The following is a description of a gene set: Any anomaly of the P wave of the EKG, which results from atrial depolarization. The P wave occurs when the sinoatrial node creates an action potential that depolarizes the atria. species: Homo sapiens Human Gene Set: HP_ABNORMAL_P_WAVE Abnormal P wave, and this is the list of marker genes: SCN5A, GJA5 (gap junction protein alpha 5), NPPA, TLL1, SCN3B, EMD (emerin)